Given this list of marker genes ITGB3, ANGPT2, SEMA5A, CALR, RHOJ, PRKD2, S100A7A, RHOA, SNAI2, EMC10, MIR26A1, PRKX, MIR129-1, ID1, CLN3, PLCG1, MIR132, EGR3, ETS1, PIK3CG, PDPK1, NRP1, NRP2, EMP2, NOTCH1, ADAMTS9, MIR503, CCBE1, CXCL13, GATA3, RAB13, FOXP1, MIR505, ACVRL1, MIR424, PRSS3, SP100, NR4A1, RRAS, ADGRB1, FGF2, PTP4A3, ITGB1, SRF, S100A8, MIR133B, S100A7L2, WNT7A, MIR29A, MIR101-1, SEMA4A, MEOX2, PECAM1, PIK3CA, EPHB4, LGALS8, CSNK2B, MIRLET7A1, PAXIP1, MIR2355, PPARG, EDN1, GLUL, CEACAM1, TGFB1 (transforming growth factor beta 1), FN1, MIR15B, SCARB1, FGFBP1, CD40, TBXA2R, MIR200B, MAP2K3 (mitogen-activated protein kinase kinase 3), MIR499A, FGF16, PRKD1, GPI, HDAC5, MEF2C, MIR143, APOE, LPXN, MECP2, FAP, MIR487B, MIR92A1, MIR193A, FLT4, MIR329-1, S100P, S100A7, PTN, HDAC9, FGF18, MIR221, LGMN, BSG, MIR30A, APOH, TMEM201, KLF4, FGF4, MIR23A, PDCD10, MIR16-1, MIR135B, EDN2, MIA3 (MIA SH3 domain ER export factor 3), SPARC, VSTM4, MIR22, AKT3, PRCP (NCBI Gene Id 5547), NR2E1, GAB1, AGT, BCAS3, ATP2B4, MIR210, MIR939, TGFBR1, ABL1, HIF1A, CDH13, PLPP3, ADGRA2, PLXND1, HRG, NUS1, ANGPT4, PLG, SH3BP1, MIR15A, CIB1, HDAC7, CYP1B1, GATA2, GRN, NF1, MICALL1, DAB2IP, SRPX2, HMOX1, TEK, AAMP, SPRED1, EFNA1, FOXC2, PTPRM, MIR27A, CLEC14A, TNFSF12, ZNF580, AGTR2, ANXA3, NOS3, MIR20A, SMOC2, MIR361, NFE2L2, BMP10, SASH1, ROCK2, LCN2, MIR206, CRIPTO (NCBI Gene Id 6997), CTNND1, CORO1B, SVBP, EFNB2 (ephrin B2), SIRT1, SLIT2, EGF, MYH9, ANXA1, MIR212, NR2F2, HSPB1, GPX1 (glutathione peroxidase 1), MIR885, TMSB4X, MIR137, HMGB1, PLEKHG5, S100A2, SP1, MIR342, CARD10, ADTRP, RAC1, RHOB, PACSIN2, PRSS3P2, PTK2B, VEGFC, MIR126, MIR149, MIR495, MIR10A, SYNJ2BP, FGF1, FGFR1, S100A9, PIK3CB, AMOT, VASH1, STAT5A, MIR494, BMPER (BMP binding endothelial regulator), FSTL1, TGFBR3, LOXL2, DCN, GDF2, MIR200C, TNF, STARD13, MIR497, PATZ1, MIR200A, KRIT1, MIR27B, MIR196A1, SCG2, MIR19B1, RIN2, ATP5F1B, GADD45A, PLK2, GIPC1, MMRN1 (multimerin 1), MIR199A1, DNAJA4, MIR152, S100A12, MIR320A, ROBO1, HSPA12B, GPLD1, ATP5F1A, JCAD, PDCD6, MIR31, MIR205, MIRLET7B, APOA1, STC1, PRKCA, KDR, STAT1, DLL4 (delta like canonical Notch ligand 4, NCBI Gene Id 54567), PTGS2 (prostaglandin-endoperoxide synthase 2), MAPK14, P2RX4, MIR29C, MIR296, MIR410, MIR24-1, PIK3C2A, WNT5A, JUP (NCBI Gene Id 3728), ATOH8, ROBO4, SERPINF1, MIRLET7F1, ITGB1BP1, ZC3H12A, MIR492, ITGB2, MIR146A, MIR10B, BCAR1, AKT1, SOX18, MET, MIR21, MMRN2, MIR640, EPHA2, ZEB2 (NCBI Gene Id 9839), PXN, ANGPT1, MIR1908, THBS1, PDGFB, PROX1, MIR483, RGCC, MAP2K5, VEGFA, CCN3, GREM1, PTK2, EHD4, MIR204, GFUS, PIK3R3, PIK3CD, CDH5, CALCA, DPP4, MIR150, FUT1, ADAM17, here is a description of the gene set: studied in species Homo sapiens The orderly movement of an endothelial cell into the extracellular matrix to form an endothelium. Human Gene Set: GOBP_ENDOTHELIAL_CELL_MIGRATION